Given this list of marker genes KDR, NRP1, PDGFRA, FBXW7-AS1, PDGFRB, here is a description of the gene set: Human Gene Set: GOMF_VASCULAR_ENDOTHELIAL_GROWTH_FACTOR_BINDING species: Homo sapiens Binding to a vascular endothelial growth factor.